Given this list of marker genes Amdhd2, Chi3l1, Chia1, Chil3, Chil6, Ctbs, Gnpda1, Ovgp1, Chil5, Chil4, Gnpda2, Chit1, here is a description of the gene set: The chemical reactions and pathways resulting in the breakdown of glucosamine-containing compounds (glucosamines). Mouse Gene Set: GOBP_GLUCOSAMINE_CONTAINING_COMPOUND_CATABOLIC_PROCESS species: Mus musculus